The following is a description of a gene set: species: Homo sapiens Human Gene Set: HP_RESPIRATORY_FAILURE A severe form of respiratory insufficiency characterized by inadequate gas exchange such that the levels of oxygen or carbon dioxide cannot be maintained within normal limits. Respiratory failure, and this is the list of marker genes: CFAP298, FARSB, CTSD, CHRNE, DNAI2, BICD2, LAMA2, IGHMBP2 (immunoglobulin mu DNA binding protein 2), CHCHD10 (NCBI Gene Id 400916), DNAJB4, BSCL2, PLP1, NKX2-1, COX7B, GMPPB, SELENON, MEG3, NFS1, EXOSC9, PON1, CCNF, UBE3B, HYDIN, TSC1, PTCD3, NEK1, TPM3, CHRNB1, IFIH1, RNU4ATAC, NDUFB11, PKHD1, TFG, VAPB, ANG, SCO2, NME8 (NCBI Gene Id 51314), FAM20C, BLM, ATXN2, DMD, NDUFAF2, CLPB, NEK10, EXOSC8, SMN1, SURF1 (SURF1 cytochrome c oxidase assembly factor), GAS2L2, NHLRC2, RSPH1, SLC2A10, LRRC56, TUFM (Tu translation elongation factor, mitochondrial), NAXE, MEGF10, LYRM7, LAMC2, GTPBP3, CCNO, MICOS13, PDHA1, OPTN, AGRN, POMT1, PON3, TBK1, CNTNAP1, RSPH4A, NDUFS4, GFRA1, MAP3K20, COL6A1, GLE1, ATXN1, DSP, GAA, PPARGC1A, LMOD3, FOXJ1, MATR3, TPM2, ODAD1, PSAP, TSFM, FGFR3, HNRNPA1, CHRNA1, CSPP1, COL12A1 (NCBI Gene Id 1304), LTBP3, GALC, DTYMK (deoxythymidylate kinase), GLS, BOLA3 (bolA family member 3), SON, AK9, ASCC1, RTL1, NFU1, HRAS, FIG4, SLC25A46, LAMA3, SARS2, ORC6, FKRP, SQSTM1, DOK7, RAPSN (NCBI Gene Id 85713), DLK1, IFNG (interferon gamma), DNAAF5, DNAAF1, RMND1, ERBB4, PDCD1, CPT2, IBA57, DNAH5, DNAJB13, SPAG1, STK36, DNAH9, ECHS1, DNAL1, AGTPBP1, DNAAF4, COL6A2, CFAP300, DNAH11, HADHA, TPI1, DRC1, GOSR2, LRP12 (LDL receptor related protein 12), ABCA3, TTC12, TRPV4, MED11, SLC25A26, LAMB3, ODAD4, GMNN, ACTA1, LRP4, AHCY, PIGA, MYL1, NUTM2B-AS1, MT-TN, EXOSC3, PRPH (NCBI Gene Id 5630), SPEF2, FHL1, SFTPB, LARGE1, CHMP2B, INVS, VCP, NDUFAF3, RSPH3, LBX1, ODAD3, ZMYND10, RPGR, RSPH9, TBCD, NUP188, MTTP, MCM4, COL13A1, TARDBP, HCCS, CFAP221, CDC45, TTN, TAF15, DNAI1, HADHB, ANXA11, RNF168 (ring finger protein 168), NME5, DCTN1, MYL2, NDUFB8, VRK1, KLHL41, DNAAF11, AMT, SUCLG1, ITGA7, HACD1, UBQLN2, MYOT, DNAAF6, IFT81, MGME1, ATAD1, OSTM1, KLHL40, ORC4, RYR1, SMAD4, COL6A3, CDC6, PEX6, TREM2 (NCBI Gene Id 54209), TSC2, DNAAF3, OFD1, DAG1, PFN1, KARS1, DNAAF2, ALG1, ORC1, CDT1, CFAP410, FLNA, SOD1, DZIP1L, UNC13A, MCIDAS, NBN, ERBB3, ASAH1, SCN4A, FUS, HTRA2, ACVR1, NEFH, POMT2, TAMM41, TK2, CCDC39, HCK, FREM2, TRMT10C, CFAP74, LRPPRC, CHRND, JUP (junction plakoglobin), DNAH1, ODAD2, PON2, MTR, GATA2, GLT8D1, TMEM70, SLC6A9, CCDC40, CRYAB, BCHE, MUSK, TSEN54, SLC34A2, NEB, NPC2, SFTPC, DAO